Given this list of marker genes PXDN, DIAPH3, CEP55, RRM2, PRC1, BIRC5 (NCBI Gene Id 332), CCNB2, ASPM, ANLN, UBE2C, CENPA, NUSAP1, here is a description of the gene set: Human Gene Set: MONTERO_THYROID_CANCER_POOR_SURVIVAL_UP Undifferentiated and poorly differentiated thyroid tumors are responsible for more than half of thyroid cancer patient deaths in spite of their low incidence. Conventional treatments do not obtain substantial benefits, and the lack of alternative approaches limits patient survival. Additionally, the absence of prognostic markers for well-differentiated tumors complicates patient-specific treatments and favors the progression of recurrent forms. In order to recognize the molecular basis involved in tumor dedifferentiation and identify potential markers for thyroid cancer prognosis prediction, we analysed the expression profile of 44 thyroid primary tumors with different degrees of dedifferentiation and aggressiveness using cDNA microarrays. Transcriptome comparison of dedifferentiated and well-differentiated thyroid tumors identified genes with >2-fold difference in absolute values and false discovery rate of <0.15. According to known molecular interaction and reaction networks, the products of these genes were mainly clustered in the MAPkinase signaling pathway, the TGF-beta signaling pathway, focal adhesion and cell motility, activation of actin polymerization and cell cycle. An exhaustive search in several databases allowed us to identify various members of the matrix metalloproteinase, melanoma antigen A and collagen gene families within the upregulated gene set. We also identified a prognosis classifier comprising just 30 transcripts with an overall accuracy of 95%. These findings may clarify the molecular mechanisms involved in thyroid tumor dedifferentiation and provide a potential prognosis predictor as well as targets for new therapies. from publication Montero-Conde C, Martín-Campos JM, Lerma E, Gimenez G, Martínez-Guitarte JL, Combalía N, Montaner D, Matías-Guiu X, Dopazo J, de Leiva A, Robledo M, Mauricio D (PMID 17873908) studied in species Homo sapiens Up-regulated genes predicting poor survival of patients with thyroid carcinoma.